The following is a description of a gene set: species: Homo sapiens Human Gene Set: GOMF_NF_KAPPAB_BINDING Binding to NF-kappaB, a transcription factor for eukaryotic RNA polymerase II promoters., and this is the list of marker genes: COMMD7, TP53BP2, DNAJA3, GSK3B, MTDH, RELA, ANXA4, CDK5RAP3, EP300, COMMD8, SETD6, PDCD11, BRMS1, PPARD, HDAC2, NPM1, COMMD6 (COMM domain containing 6), CDKN2A, TAF4B, AKAP8, HDAC1, HIF1AN, PSMA6 (NCBI Gene Id 87553), ANKRD42, CPNE1, FOXP3, BCL10, FAF1, HDAC3, RNF25, NFKBIA, NOTCH2